Given this list of marker genes STIL, FUZ, DOCK6, VSX1, ARHGAP31, TCOF1, GMPPB, HOXD13, SIN3A, IGF2, GDF6, PIBF1, TCTN1, TMTC3, NPHP1, TMEM216, CDON, CBY1, ARPC4, CRX (NCBI Gene Id 1406), KIAA0753, DISP1, TBX15, RDH12, ZIC2, GLI2, FKRP, FREM2, RD3, GAS1, SUFU, NMNAT1, TMEM218, CEP41, ARL13B, USP45, VANGL2, INPP5E, ZSWIM6, LARGE1, GPKOW, SMO, CEP120, B9D2, TCTN3, PAK2, PORCN, MSX2, FKTN, SF3B2, ARMC9, ZNF423, IFT140, IMPDH1, ZIC3, FILIP1, NDE1, LAMB1, TMEM138, ESCO2, NUAK2, POLR1D, IFT74, SPATA7, ALX1, GUCY2D, DACT1, LCA5, FGFR1, DLL1, TBXT, IQCB1, GRIP1, KCNJ13, NOTCH1, MKS1, ESAM, POMGNT1, CRPPA, H19, FLVCR2 (NCBI Gene Id 55640), CRIPTO, KCNQ1OT1, CEP290, FRAS1, TRIM36, DRG1, FLNB, POMT2, POLR1B, FOXH1, GLI3, CCL2, EOGT, FLNA, CEP55, KIF7, PAX3, HES7, OFD1, CPLANE1, ALX4, CYP26B1, CC2D2A, POMT1, POMK, TCTN2, B9D1, PCYT1A, RPE65, BMPER, SIX3, POLR1C, PIK3CA, PTCH1, TMEM107, KIAA0586, TGIF1, SNRPB, C2CD3, SHH, AHI1 (Abelson helper integration site 1), VANGL1 (NCBI Gene Id 81839), ALX3, PHGDH, TUBB4B, RBPJ, LRAT, TXNDC15, RPGRIP1L, RPGRIP1, B4GAT1, TMEM237, AIPL1, TMEM67, HYLS1, CSPP1, PDE6D, NODAL, FGF8 (fibroblast growth factor 8), FGFR3, TULP1, DLL4, WDR81, HSPG2, COL18A1, TOGARAM1, CRB1, CEP104, ARL3, KATNIP, TMEM231, here is a description of the gene set: Human Gene Set: HP_OPEN_NEURAL_TUBE_DEFECT Open neural tube defect A type of neural tube defect that is not covered by skin. species: Homo sapiens